The following is a description of a gene set: Genes predicted to be targets of miRBase v22 microRNA hsa-miR-4711-5p in miRDB v6.0 with MirTarget v4 prediction scores > 80 (high confidence targets). from publication Chen Y, Wang X (PMID 31504780) species: Homo sapiens Human Gene Set: MIR4711_5P, and this is the list of marker genes: CTTN, DYNLL1, GALK2, PAPOLA, LRCH2, TMPO, MSL2, ALG13, KIF2A, OGDH, TRAPPC8, PHF8, BEGAIN, R3HDM1, PDE3B, TMBIM4, EVI2A, AAK1, WNT3A, RAVER1, CHST14, CMTR2, RPGRIP1L, USP47, APCDD1, ELAVL4, CBFB, HECTD4, NCAPH2, GABPA, POU2AF3, PNN, ATRN, CIAO2A, TMEM30A, UBAC2, MGST2 (NCBI Gene Id 4258), LAMC2, GINS2, RAB11FIP2, WDFY3, ZFHX4, N4BP2L1, HECW2, LUZP1, MBNL2, FBXO28, SBF2, ICA1L, AGO4, SCN4B, FGF9, SLC31A1 (NCBI Gene Id 1317), RORA, TRIM41, DMXL1, SUPT7L, KPNB1, DIO2, MID2, USP29, NXPE4, DR1, KRT10, SLC24A4, PPP2R2B, ZDHHC15, BACH2, LMO7, PAPSS2, GTF3A (NCBI Gene Id 2971), CACNA1H, MTSS1, NAV2, ZFHX3, CH25H, HDDC3, PPP4R2, COL12A1, CASZ1, KCNJ10, PTPRE, CCDC102A, CCR2, HDAC8, NRCAM, RYR2 (ryanodine receptor 2), TTBK2, TNFAIP8L3, FAT1, RUVBL1, CLEC5A, SLC44A1, ATP2B1, ZDHHC17, ADGRL3, MOSMO, MYT1, LARP4B, YIPF4, GADD45A, DIDO1, ZNF333